The following is a description of a gene set: Genes predicted to be targets of miRBase v22 microRNA mmu_miR_7008_5p in miRDB v6.0 with MirTarget v4 prediction scores > 80 (high confidence targets). studied in species Mus musculus from publication Chen Y, Wang X (PMID 31504780) Mouse Gene Set: MIR_7008_5P, and this is the list of marker genes: Mbnl3, Tcte1, Trp53inp2, Prss32, Marf1, Hnrnpu, Trnp1, Atf6, Cyp4v3, Trpc3, Zmiz1, Myef2, Pklr, Ap1g1, Adamts17, Ephb2, Slco1a5, Ttc7, Scn4b, Sfmbt2, Ezh1, Trpd52l3, Cry2, Kdm2a (lysine (K)-specific demethylase 2A), Psg22, Bptf, Tnfsf13 (NCBI Gene Id 69583), Igf2bp2, Grik3, Krtap4-2, Psg19, Brpf3 (NCBI Gene Id 268936), Fam53c, Nr6a1, Parp11, Psg21, Dapl1, Vps25, Gria2, Atg10, Plpp6, Fev, Gjc3, Iqsec3, Gpr149, Ttc9, Slc26a5, Tnfsfm13, Fbxw9, Git1, Lyl1, Acsf2, Limch1 (LIM and calponin homology domains 1), Cyp2c55, St8sia6, Wnt1, Eya1, Phc2, Dagla, Slc2a4, Cd37, Dtna, Htra3, C2cd2l, Gm867, Tbr1, Krtap4-6, Dnajb13 (DnaJ heat shock protein family (Hsp40) member B13), Ptp4a1, Stk35, Shisal1, Sash3, Ctsw, Wars1, Psg17, Adcyap1r1, Psca (prostate stem cell antigen), Cdk6, Vash2, Ldb3, Xirp1, Cp, Khnyn, Cntn4, Atxn1l, Pmm2, Mief1, Gba2, Sftpa1, Reln, St8sia3, Acer2, Yif1b, Gars1, Dlg4, Fam89b, Arhgef2, Bbln, Me3, Grb10, Psg26, Ppp4c, Xylt2, Hpcal4